Given this list of marker genes STAT5A, NRG4, SHC1, PIK3R1, JAK2, ITCH, PRLR, PIK3CD, MAPK3, BTC, MDM2, PIK3CB, GRIN2B, HBEGF, TAB2, YAP1, FYN, WWOX, STAT5B, ADAM17, PIK3R2, NRG2, MAPK1, ERBB2, NCOR1, DLG4, NEDD4, PIK3CA, PRL, ERBB4, WWP1, CBFA2T3, PIK3R3, GRB2, LRIG1, EREG, NRG1, NRG3, here is a description of the gene set: ErbB4 signaling events from publication Schaefer CF, Anthony K, Krupa S, Buchoff J, Day M, Hannay T, Buetow KH (PMID 18832364) studied in species Homo sapiens Human Gene Set: PID_ERBB4_PATHWAY